Given this list of marker genes GMPPB, LRP4 (LDL receptor related protein 4), MYPN, TPM3, CHRND, ACADM, NR3C1, MUSK, TOE1, ACTA1, COL13A1, CHRNA1, SYNE1, CFL2, USP8, STIM1, FLNC, TPM2, SCN4A, CHRNE, AK9, TP53, LDB3, TFG, USP48 (ubiquitin specific peptidase 48), MINPP1, RAPSN, SLC18A3, CDH23, DOK7, FKRP, HINT1, CASQ1, AGRN, LARGE1, KLHL41, POMT2, KCNK9, NEB, BRAF, ORAI1, ATRX, LMOD3, CHRNB1, POMT1, here is a description of the gene set: A type of weakness of skeletal muscle that occurs after a muscle group is used and lessens if the muscle group has some rest. That is, there is diminution of strength with repetitive muscle actions. species: Homo sapiens Fatigable weakness of skeletal muscles Human Gene Set: HP_FATIGABLE_WEAKNESS_OF_SKELETAL_MUSCLES